The following is a description of a gene set: An abnormality characterized by chronic impairment of the normal functioning of the axons. Chronic axonal neuropathy species: Homo sapiens Human Gene Set: HP_CHRONIC_AXONAL_NEUROPATHY, and this is the list of marker genes: SPTLC1, COG8, HSPB1, GDAP1, KCNJ10, SETX, SYNE1